The following is a description of a gene set: species: Mus musculus Mouse Gene Set: GOBP_NEGATIVE_REGULATION_OF_GLYCOGEN_METABOLIC_PROCESS Any process that stops, prevents, or reduces the frequency, rate or extent of the chemical reactions and pathways involving glycogen., and this is the list of marker genes: Ppp1r3b, Ins2, Adra1b, Gsk3b, Enpp1, Grb10, Prkag3, 1810024B03Rik, Inpp5k, Gfpt1, Pask, Ins1